The following is a description of a gene set: Hypovolemic shock A state of shock characterized by decreased circulating blood volume in relation to total vascular capacity. This type of shock is characterized by a reduction of diastolic filling pressures. Human Gene Set: HP_HYPOVOLEMIC_SHOCK species: Homo sapiens, and this is the list of marker genes: SCNN1A, JUP (NCBI Gene Id 3728), SCNN1B, DSP, SCNN1G